The following is a description of a gene set: The series of molecular signals in which a stress-activated protein kinase (SAPK) cascade relays a signal. Human Gene Set: GOBP_STRESS_ACTIVATED_PROTEIN_KINASE_SIGNALING_CASCADE studied in species Homo sapiens, and this is the list of marker genes: GREM1, MAP3K13, MYC, MAP2K6, MAPK8, INAVA, MAP3K7, TLR4, DUSP10, MID1, CCM2, SEMA4C, MAP2K3, PAGE4, IGFBP6, FAS, CD2AP, RIPK2, CARD9, IL26, GSTP1, MAPK8IP2, MAPK3, MAPK1, MAP2K2, TAOK1, GFRAL, PPIA (peptidylprolyl isomerase A), FOXO1, MAPK13, MAPK14, KLHDC10, NOD1, TAOK2, EIF2AK2, MAP3K5, STK25, NBR1, MAP3K20, KAT7, PDCD10, ZMPSTE24, SCIMP, MAP2K1, MAPK11, QARS1, TAOK3, FOXM1 (forkhead box M1), IKBKB, ARL6IP5, TGFB2, CRYAB, IGBP1, PBK, MAP2K7, NOD2, PRDX1